Given this list of marker genes FZD4, FZD6, WNT3A, RNF43, FZD8, LRP5, LRP6, FZD5, here is a description of the gene set: Human Gene Set: REACTOME_SIGNALING_BY_RNF43_MUTANTS studied in species Homo sapiens Signaling by RNF43 mutants